The following is a description of a gene set: Any process that modulates the rate or extent of the tumor necrosis factor-mediated signaling pathway. The tumor necrosis factor-mediated signaling pathway is the series of molecular signals generated as a consequence of tumor necrosis factor binding to a cell surface receptor. species: Mus musculus Mouse Gene Set: GOBP_REGULATION_OF_TUMOR_NECROSIS_FACTOR_MEDIATED_SIGNALING_PATHWAY, and this is the list of marker genes: Sharpin, Sphk1, Pycard, H2bc21, Ripk1, Cyld, Naip6, Adam17, Tjp2, Nr1h4, Naip5, Ext1, Ppp2cb, Hspa1b, Pias3, Nol3, Mmp8, Traip, Syk, Laptm5, Tank, Ccdc3, Tnfrsf11b, Naip1, Ptpn2, Naip2, Prkn, Hipk1, Traf2, Ube2k, Casp1, Gps2, Cldn18, Spata2, Dicer1, F2rl1, Trim32, Otulin, Apoa1, Xiap, Birc7, Cpne1, Rffl, Adipoq (NCBI Gene Id 11450), Pias4, Tmc8, Gas6, Peli3, Nkiras1, Nkiras2, Tnfrsf1a